Given this list of marker genes THAP1, CDH7, BRINP3, ZNF713, YRDC, CEBPG, SLC16A1, DDX10, FSCN1, TXN (NCBI Gene Id 7295), GPR22, DUT, KIF9, ZNF687, WHAMM, KCNJ3, LRRK2 (NCBI Gene Id 399472), F13B, FBXL8, HOXA6, SEMA3C (NCBI Gene Id 222200, semaphorin 3C), ABCE1, TNFRSF10B, MMP7, TAS2R45, FAM240C, MGLL, ZNF142, CD200, KREMEN2, ZNF208, PAXIP1-AS2, NFE2L1, ST20, SIX5, MTMR2, CPNE9, PIKFYVE, SLC15A4, DOCK9, CHRNA1, SERP1, HTT, MKNK2, PSMA4, ENPP5, MAP3K5, CLPB, GPATCH4, CCR1, NUDT19, ANKRD16, SLC35B2, UBAP2, PPTC7, EIF1B, PXDNL, IRF5, CD320, CD80, BATF3, RBMXL1, C20orf202, SNTB1, NUP62, VTI1A, TJP2, NFKBID, CCDC190, MATN3, MAGEA1, FOXJ3, CCDC50, CALML4, HAS2, ONECUT2, ARHGAP12, SLC35D3, DDX52, KRTAP4-8, LINC00592, KHSRP, IL4I1, ACSL1, SLAMF1, LCN12, NTPCR, NDUFS1, SUPT3H, CASZ1, TCF7L2 (transcription factor 7 like 2), MSRB3, NINJ2, TESC, SLIRP, GADD45B, GATAD2B, MYCBP2, SNX11, EXOC5, OLFM2, TNFRSF10A, CXCL11, CYP27B1, SURF2, ACBD6, KCTD18, FAM182A, PLPPR3, TMEM139, ACKR3, PCDH7, NEDD4L, JAM2, EPM2A, CCL22, CACNG1, BCL2L1, STATH, EBNA1BP2, U2AF2, MBD5, BICRAL, CAPNS2, XPNPEP3, EYA4, RPS6KC1, RPL11, PTGER4, SLC25A33, ARID5A, AHCY, DCP1A, DPCD, SGCB (sarcoglycan beta), TRMT11, SHB, BCL2A1, SPINT1, RUNX3, IL6, DDI1, SAMD11, OTUD1, CDC34, GPR55 (NCBI Gene Id 9290), KCNV2, SORBS2, RBM26-AS1, KCNJ6, DNAJC5B, EEF1B2, RAB12, UBASH3A, TAGLN2, PRKAA2, AGO2, PLEC, GAS7, TMEM52, ISG20L2, SAMSN1, KSR1, SHE, POTEM, DIRC1, HEPACAM2, NME9, RNF40, PELP1, TSPYL4, YWHAE, MIR3945HG, TET3, CIMIP2A, BTN2A2, TOMM70, TNFSF14, TMC6, SIRT4, SLC35E4, ETFRF1, INSC, NKX3-1, RPS15A, ATF7IP, NFKBIA, DDX21, CABS1, PENK, FAM171A1, BCAT1, TNFRSF8, here is a description of the gene set: studied in species Homo sapiens from publication Xu Z, Potula HH, Vallurupalli A, Perry D, Baker H, Croker BP, Dozmorov I, Morel L (PMID 21543644) Genes down-regulated in lupus susceptibility locus Sle2c1 B lymphocytes from: peritoneal cavity versus spleen. Sle2c1 is an NZM2410-derived lupus susceptibility locus that induces an expansion of the B1a cell compartment. B1a cells have a repertoire enriched for autoreactivity, and an expansion of this B cell subset occurs in several mouse models of lupus. Here we showed that expression of Sle2c1 enhances NZB cellular phenotypes that have been associated with autoimmune pathogenesis. A combination of genetic mapping and candidate gene analysis presents Cdkn2c, a gene encoding for cyclin kinase inhibitor p18INK4c (p18), as the top candidate gene for inducing the Slec2c1 associated expansion of B1a cells. A novel SNP in the Cdkn2c promoter is associated with a significantly reduced Cdkn2c expression in the splenic B cells and B1a cells from Sle2c1-carrying mice, which leads to defective G1 cell cycle arrest in splenic B cells and increased proliferation of Pc B1a cells. As cell cycle is differentially regulated in B1a and B2 cells, these results suggest that Cdkn2c play a critical role in B1a cell self renewal, and that its impaired expression leads to an accumulation of these cells with high autoreactive potential. Human Gene Set: GSE23114_PERITONEAL_CAVITY_B1A_BCELL_VS_SPLEEN_BCELL_IN_SLE2C1_MOUSE_DN